The following is a description of a gene set: Mouse Gene Set: GOBP_REGULATION_OF_MORPHOGENESIS_OF_AN_EPITHELIUM Any process that modulates the frequency, rate or extent of morphogenesis of an epithelium. species: Mus musculus, and this is the list of marker genes: Btbd7, Gja1, Sirt6, Gdnf, Stox1, Fgf2, Mdk, Tnf, Hoxb7, Gata3, Sulf1, Agtr2, Lif, Tacstd2, Wnt2b, Pax2, Ntn4, Alox12, Pdgfra, Snai2, Adamts12, Hgf, Sox8, Tbx2, Wnt2 (NCBI Gene Id 93808), Agtr1a, Ar, Fgf1, Smo, Met, Bmp4, Mmrn2, Cdh1, Hoxd13, Fgf10, Sall1, Rnf207, Wnt5b, Agtr1b, Foxp1, Bmp7, Agt, Fgfr1, Fkbpl, Cav3, Wnt5a, Maged1, Fgf7, Etv5, Esr1, Lcn2, Tgfb1, Shh, Wnt4, Vegfa, Lhx1, Six1, Itgax, Pax8, Egf, Sfrp1, Cxcl10, Pik3cd, Lgr4, Lbx2, Phb2, Sox9, Grem1, Rxra, Abl1, Six4, Nog, Pdgfa, Ctnnb1, Six2